Given this list of marker genes TELO2, FBLN1, COL1A1, CLTCL1, PLOD1, COL12A1, SHROOM4, here is a description of the gene set: studied in species Homo sapiens Human Gene Set: HP_CONGENITAL_BILATERAL_HIP_DISLOCATION Congenital bilateral hip dislocation